Given this list of marker genes Lck, Skint1, Lef1, Sox13, Ptprc, Gimap3, Sox4, Syk, Stat5b (NCBI Gene Id 20851), Gimap5, Stat5a, Nckap1l, here is a description of the gene set: Mouse Gene Set: GOBP_POSITIVE_REGULATION_OF_GAMMA_DELTA_T_CELL_ACTIVATION species: Mus musculus Any process that activates or increases the frequency, rate or extent of gamma-delta T cell activation.